The following is a description of a gene set: This event has been computationally inferred from an event that has been demonstrated in another species.<p>The inference is based on the homology mapping from PANTHER. Briefly, reactions for which all involved PhysicalEntities (in input, output and catalyst) have a mapped orthologue/paralogue (for complexes at least 75% of components must have a mapping) are inferred to the other species. electronically inferred by orthology from the curated human pathway species: Mus musculus part of: Sensory Perception Reactome Pathway: Visual phototransduction, and this is the list of marker genes: Pde6b, Gucy2f, Sdr9c7, Rbp4, Sdc1, Hsd17b6, Akr1b10, Akr1c13, Rgs9bp, Gngt1, Rdh5, Apoc3, Camkmt, Gpihbp1, Pde6g, Dhrs9, Rbp2, Rho, Gpc3, Bco1, Cnga1, Sdc3, Apoe, Rbp1, Apoa2, Akr1c21, Akr1c20, Dhrs3, Sag, Rgs9, Guca1a, Gpc2, Opn1sw, Awat2, Lpl, Stra6, Akr1c14, Lrp1, Apoa1, Akr1c6, Nmt1, Lrp12, Lrp10, Fnta, Rdh12, Lrp8, Cngb1, Pnlip, Apoc2, Myo7a, Akr1c18, Rdh10, Ppef1, Apob, Apoa4, Cyp4v3, Gnb5, Calm1, Gnat1, Bco2, Rcvrn